The following is a description of a gene set: Reactome Pathway: Beta oxidation of palmitoyl-CoA to myristoyl-CoA part of: mitochondrial fatty acid beta-oxidation of saturated fatty acids This first pass through the beta-oxidation spiral starts with the saturated fatty acid palmitoyl-CoA and produces myristoyl-CoA. Four enzymatic steps are required, starting with VLCAD CoA dehydrogenase (Very Long Chain) activity, followed by three enzymatic steps, enoyl-CoA hydratase, 3-hydroxyacyl-CoA dehydrogenase, and ketoacyl-CoA thiolase activities, all present in the mitochondrial membrane associated trifunctional protein. species: Homo sapiens, and this is the list of marker genes: HADHA, HADHB, ACADVL